Given this list of marker genes Impg1, Rtbdn, Rbp3, Impg2, Vcan, here is a description of the gene set: studied in species Mus musculus Mouse Gene Set: GOCC_INTERPHOTORECEPTOR_MATRIX A specialized extracellularc matrix that surrounds the photoreceptors of the retina and lies between them and the apical surface of the retinal pigment epithelium. The IPM has been implicated in several important activities required for photoreceptor function and maintenance.